Given this list of marker genes Htr2a, Hsp90aa1, Ehmt2, Tgm2, Bdnf, Crh, Drd3, Parp1, Tacr3, Oprk1, Elavl4 (ELAV like RNA binding protein 4), Pgr, Adra1b, mt-Nd6, Myrf, Crhbp, Hnmt, Gprin3, Arc, Cnr1, Gria1, Dlg4, Mecp2, Smpd1, Ccna2, Drd1, Xlr4b, Fosb (FBJ osteosarcoma oncogene B), Crebbp, Grm2, Oxtr, Cacng4, Drd4, Comt, Ptk2b, Homer2, En1, Ube3a, Slc1a3, Crhr1, St8sia2, Adgrl3, Mdm2, Xlr4a, Nos1, Dnmt3a, Cdk5, Abat, Hdac5, Pitx3, Snca, Slc6a3, Slc1a1, Htr1b (NCBI Gene Id 15551), Ncam1, Drd2, Slc6a4, Oxt, Gad2, Chrnb2, Drd5, Ppp1r1b, Slc1a2, Homer1, Mtor, Fkbp5, Sdk1, Fadd, here is a description of the gene set: studied in species Mus musculus Mouse Gene Set: GOBP_RESPONSE_TO_COCAINE Any process that results in a change in state or activity of a cell or an organism (in terms of movement, secretion, enzyme production, gene expression, etc.) as a result of a cocaine stimulus. Cocaine is a crystalline alkaloid obtained from the leaves of the coca plant.